The following is a description of a gene set: species: Homo sapiens Human Gene Set: FREAC7_01 Genes having at least one occurrence of the motif WNNANATAAAYANNNN in the regions spanning 4 kb centered on their transcription starting sites. This matches the FOXL1 transcription factor binding site V$FREAC7_01 (v7.4 TRANSFAC)., and this is the list of marker genes: C17orf78, PMCH, TSHB (thyroid stimulating hormone subunit beta), PTF1A, MAGED2, POU2F1, CREBRF, IBSP, UBE2H, ARHGAP30, FLRT3, PRR34 (PRR34 long non-coding RNA), SSBP3 (NCBI Gene Id 55126), PIK3C2A, LINC03124, RHOB, TGFB2, CTNNAL1, BAMBI, CRH, TNFSF15, OGG1, DLG2, LCP2, PLAG1, EN2, GATA4 (NCBI Gene Id 2626), GRM3, FOXD3, CH25H, RUNX2, NDST4, PREX2, NEDD4 (NEDD4 E3 ubiquitin protein ligase), TCEAL7, BUB3, HOXB4, TYR, C12orf57, ELK3, ZHX2, SYT6, PTGR3, LDOC1, RTL9, CADM1, STOML2, GAL3ST4, CACNA2D3, PNPLA6, TSPYL2, CLDN23, PPP1CB, NEIL3, HCAR3, SPTB, SNCAIP, TRIM8, CHCHD7 (coiled-coil-helix-coiled-coil-helix domain containing 7), PCDH11X, RAB6C, BNC2, EXD2, NIN, FGF9, MSL3, HOXA10, HOXC4, PACSIN3, CCDC140, KRT84, BRAF, OPA3, RGMA, MSTN, SBF2, SEMA6D, TYRO3, PLEC, CDC42EP3, NOVA1, C8orf82, SDHD, STX19, HAND2, LINC01138, CGA, PRPF18, DNAJA4, EPCIP, CCDC174, POGZ, RNF17, SEL1L3, PTCH1, HCAR2, ASIC2, NFIB, EPYC, IL17C, SOHLH2, TIMM8B, NFYA, CSNK1G3, LBX2-AS1, IFNA10, UCKL1, JUNB, DRG1, COL13A1, IL25, CXCL2, CDAN1, CSF3, KCTD15, GDPD3, CCN2, CSNK1E, HIVEP3, PARP8, NFRKB, PABIR1, TAFAZZIN, RP1, NTF3, UBR1, LINC00299 (long intergenic non-protein coding RNA 299), C12orf50, GOLGA1, SCUBE3, SCML1, PPP2R2B, DENND4C, PAX3, CPEB4, SSH3, CXXC5, SLC10A7, FBXO11, EN1, HESX1, FLOT1, ALKBH5, GALNT1, CBX6, ALPL, PCDH11Y, DTNA, TOGARAM2, KCNQ5, VCPKMT, ERRFI1, MID1, EPN1, ATP1B4, ETV5, TCF7L2, RHOBTB1, VCP, PIAS1, OARD1, FST, IKZF2, ADGRB3, SLC25A51, PRKAG1, EFNA5, TWIST1, NEUROD2, NEUROD6, FRMD4A, GTF2A1, NRAS (NRAS proto-oncogene, GTPase, NCBI Gene Id 4893), MGLL, NPVF, ZBTB18, CELF4, ADGRF1, LINC01931, RAB5B (RAB5B, member RAS oncogene family, NCBI Gene Id 5869), NPPB, HMCN1, BCL11B, HOXA11, ELMO1, SOX2, DMPK, PCDHB6, LNPK, MXRA8, ABCA1, ZBTB20, IER3, BEX2, ENSG00000255537, TSHZ3, NRG1, CLDN8, LINC03122, FEZ1